The following is a description of a gene set: Genes predicted to be targets of miRBase v22 microRNA hsa-miR-4639-5p in miRDB v6.0 with MirTarget v4 prediction scores > 80 (high confidence targets). species: Homo sapiens from publication Chen Y, Wang X (PMID 31504780) Human Gene Set: MIR4639_5P, and this is the list of marker genes: KRTAP3-1, ZNF281, PTPN4, PRIMA1, BVES, LRRC75A (NCBI Gene Id 388341), EDIL3, KCTD3, CCDC85A, HYDIN, CRISPLD1, NRG4, KDM4A, GJB7, CRH, B4GALT1, BMP3, TET2, ST8SIA5, GABRA1, ZNF737, SLC35F3, SLC6A8, IRF2BPL, USP48, AMELY, CLEC1A, MAP4K5, RNF216, CPSF2, CPD, MIPOL1, TDRD7, MCTS1, GOLPH3, ANKRD20A2P, SLC35A5, CNOT7, MRTFB, PHYHIPL, ZNF236, SV2C, MAGI3, FMNL2, KRT28, MBNL2, EBLN2, ANXA7, ZPBP2, CHD9, DCAF12L1, CHN2, NUP50, ZBTB21, DYNLL2, TOX, PTPRB, GALNT16, TMEM126B (NCBI Gene Id 95018), CAMTA1, BICD2, MEDAG, ATG4C, PPCS, WASHC2A, MED29, FTHL17, WASHC2C, NEFH, MYO1D, ANKRD20A4P, STK39, OR2H1, NFATC2 (nuclear factor of activated T cells 2), BLOC1S5, FOXP2, PKIA, ANKRD20A1, OPRK1, FREM3, YEATS4, ANK3 (NCBI Gene Id 288), UNC13D, RRAGA, NRG2, UBE3C, MBOAT2, KHDC4, ZNF710, STXBP5L, DDHD1, CACNA1B, CCDC117, CAB39, HIF1A, PFN2, AMELX, PRICKLE2, ZBTB20